Given this list of marker genes FAM98B, KCTD12, LRRC14, MRPS27 (mitochondrial ribosomal protein S27), TRMT1, HAUS8 (NCBI Gene Id 93323), TP53RK, DSTYK, SKP2, UTP25, SRGAP1, NTMT1, ASB6, RPL7L1, ZNF317, PLXNA1, YLPM1, ARL2BP, MMS19, RXRA, SMAD5, INIP, SLC9A5, NAXD, EHMT1, HRAS (NCBI Gene Id 338029), ZNF251, MTFR1L, MRPL34, RNF185, VASH1, KIAA0232, RANGRF, FBXO21, DHX30, MTFMT, BCR, RPS19BP1, FAM98A, NDUFA5, IRF5, COQ9, TFPT, TUBA4A, BRF2, ATXN1, LIMA1, RNF7, CERK, FIS1, TRAK2, PABPN1, CD2BP2, EXOSC7, PPP1R14B, GATC, RUNX1, SUV39H2, FBXO45, NUDT16, CDK4, TRIT1, JADE1, THBD, LRR1, UTP11, ADRM1, FAM78A, TAF4, DNAJC11, SEC14L1, MAP1A, NAIF1, USP38, PTPDC1, SNX30, ZNF559, NACC2, UMPS, CDC40, NOL12, ARL3, GEMIN6, MED8, MRFAP1L1, SURF6, BCCIP, CASD1, ZCCHC17, ZNF420, FHOD1, TBC1D10A, CDR2, CDCA4, URB2, SFN, PPCS, HSD17B10, C5orf24, SRSF8, PHF13, ENC1, TRMT10C, SDHAF1, TMEM273, RAB33A, AVPI1, TAF5L, NUDT4, KLHL21, MEX3B, KAT14, ASB1, DDX20, MAGOH-DT, ZNF823, DFFA, CIAPIN1, YOD1, FBXO33, TRPV2, FAM89B, KLHL42, IFNGR1, ZYG11B, PHF23, HMG20B, SLTM, MTOR, CCDC12 (NCBI Gene Id 151903), TACC1, ATP5PO, POLR2D, PMS2P9, SPDL1, TNFSF14, TIMM21, POLR3B (NCBI Gene Id 55703), BAHD1, ZCCHC24, PDE6D, POLR1C, NOL11, IL16, TSPYL5, GBA2, SLC19A2 (solute carrier family 19 member 2), WFDC21P, CCDC168, ATPAF2, MTNAP1, CXXC1, SSH2, HIVEP3, PET100, PNP, TRAF3, RIN3, NME3, SGK1, PLEKHJ1, ACVR2B, PRKAB2, SNAI3, FKBP14 (FKBP prolyl isomerase 14), PHF1, PRDM15, LCMT2, ZC3HC1, AKTIP (NCBI Gene Id 64400), GXYLT1, FAM168B, ORC2, BLMH, TRIM32, ZNF35, CSRP1, ACAD8, IFNGR2, ENDOG, CMTM4, MRTO4, POLR2I, INTS11, C9orf40, NCAPH, EXO5, RNF4, ATP2A3, ASTE1, MFN2, EIF4ENIF1, FRAT2, UBAC1, RRS1, IGF1R, DCAF4, DOK2, here is a description of the gene set: Genes up-regulated in comparison of control conventional dendritic cells (cDC) at 10 h versus cDCs infected with Newcastle disease virus (NDV) at 10 h. species: Homo sapiens Human Gene Set: GSE18791_UNSTIM_VS_NEWCATSLE_VIRUS_DC_10H_UP The dendritic cell (DC) is a master regulator of immune responses. Pathogenic viruses subvert normal immune function in DCs through the expression of immune antagonists. Understanding how these antagonists interact with the host immune system requires knowledge of the underlying genetic regulatory network that operates during an uninhibited antiviral response. In order to isolate and identify this network, we studied DCs infected with Newcastle Disease Virus (NDV), which is able to stimulate innate immunity and DC maturation through activation of RIG-I signaling, but lacks the ability to evade the human interferon response. To analyze this experimental model, we developed a new approach integrating genome-wide expression kinetics and time-dependent promoter analysis. We found that the genetic program underlying the antiviral cell state transition during the first 18-hours post-infection could be explained by a single regulatory network. Gene expression changes were driven by a step-wise multi-factor cascading control mechanism, where the specific transcription factors controlling expression changed over time. Within this network, most individual genes are regulated by multiple factors, indicating robustness against virus-encoded immune evasion genes. In addition to effectively recapitulating current biological knowledge, we predicted, and validated experimentally, antiviral roles for several novel transcription factors. More generally, our results show how a genetic program can be temporally controlled through a single regulatory network to achieve the large-scale genetic reprogramming characteristic of cell state transitions. from publication Zaslavsky E, Hershberg U, Seto J, Pham AM, Marquez S, Duke JL, Wetmur JG, Tenoever BR, Sealfon SC, Kleinstein SH (PMID 20164420)